Given this list of marker genes NLN (neurolysin), RNF180, CKS1BP3, CWC27, DEPDC1B, LINC02997, LINC02229, SHLD3, SGTB, TRAPPC13, RNU6-913P, PPWD1, SMIM15-AS1, RNU6-806P, ADAMTS6, LINC02065, HTR1A, RNU6-294P, ENSG00000286062, ENSG00000304711, ENSG00000248529, ELOVL7, PDE4D, MAST4, DIMT1, LRRC70, RPL35AP14, KIF2A, MAST4-AS1, NDUFAF2, SHISAL2B, LINC03123, ERCC8-AS1, TILRLS, PART1, ISCA1P1 (iron-sulfur cluster assembly 1 pseudogene 1), ENSG00000252904, LINC02057, ERBIN-DT, IPO11, KRT8P31, GNL3LP1, MRPL49P1, RGS7BP, ERBIN, ERCC8, SREK1IP1, RPL31P8, RN7SL169P, PPIAP78, NT5ELP (NCBI Gene Id 118568826), TRIM23, RNU6-540P, CAB39P1, MIR582, RN7SKP157, LINC03122, SMIM15, CD180, SREK1, CENPK, RNU6-661P, MAST4-IT1, RPEP1, ZSWIM6 (NCBI Gene Id 57688), SETP21, RPL3P6, here is a description of the gene set: Human Gene Set: chr5q12 species: Homo sapiens